The following is a description of a gene set: Genes having at least one occurrence of the motif RWAAACAANNN in the regions spanning 4 kb centered on their transcription starting sites. This matches the MLLT7 transcription factor binding site V$FOXO4_01 (v7.4 TRANSFAC). studied in species Homo sapiens Human Gene Set: FOXO4_01, and this is the list of marker genes: CACNA2D2, SZT2, TRERF1, DPH1, LMO4, CSNK1G3, EPN1, ADGRL2, SH3GL3, TRPM3, WFIKKN2, CADM2, EZH1, MSMB, HOXB8, MIDEAS, RBL2, CBFA2T2, SLITRK5, INHBA, BRD8, SNCAIP (synuclein alpha interacting protein), LINC00173, NFIB, HCAR3, STX16, ADGRL1, LRRC1, HHIP, KRT86, MEIS2, RASD1, NDRG1, PURA, RASSF6, FGF14, PTCH1, POLR2L, NFATC3, MTMR2, HOXB4, DCAF11, TM9SF3, LRRTM3, PITPNC1, TAF5, PCDHB15, HR, CSMD3, KDM3A, NR3C1, PXK, LUC7L3, DENND2B (NCBI Gene Id 6764), PAQR9, ABLIM3, HOXC10 (NCBI Gene Id 3226), HOXC4, THRA, EXT1, ZFYVE9, SLC12A6, HCAR2, CNPPD1, NEO1, LINC03122, GATA6, NRG1, CPNE1, ITGA1 (NCBI Gene Id 3672), HESX1, VASN, ZNF366, PRKAG1, RTL9, PALM, CEP120, LZTS2, ENPP2, FAM53C, PRDM1, TXNDC12, FGF9, SLC4A4, BIK, ASXL1, IL6ST, IRS4, SLC36A2, PTH1R, TBCC, RP1, CEP83, ID2, AP1G2, HOXA10, VLDLR, TJP1, OLIG3, MARCKSL1, HDAC9, KLF12, FST, PELO, ADAM12, SESN3, DHRS3, ETV5, PLAG1, RBMXL2, TLX3, EIF4G1, AKAP10, RANBP10, CREBRF, ZHX2, ISL1, C12orf50, COL8A1, KIF20A, ZBTB18, MAML3, RUNX1, PDCD4, TSPAN13, AZI2, SLC10A7, SATB2, KDM6A, RETREG2, ARRDC3, TSPAN4, CACNG2 (NCBI Gene Id 10369), NMNAT2, GPR18, EPHB1, PTP4A3, MAP3K3, FSTL1 (follistatin like 1), RARA, H3-3B, BDNF, SMURF2, VIT, ETV4, NDST4, PTCHD1, PTCHD4, MBNL1, TOP1, OTX2, ARHGEF38, IMPDH2 (inosine monophosphate dehydrogenase 2), ATOH8, C1QTNF3, FOXG1, CRTC2, CHCHD7, CCN1, GPR137B, KMT2E (lysine methyltransferase 2E (inactive)), ATXN7L1, CELF6, KY, DST, BCL11B, ATF7IP, INSRR, NYAP1, MSC, SLC26A7, SHOX2, CALM2, PDE4D, ABCC5, CADPS, TJP2, FCHSD2, ZNF385B, MPC2, UBE2H, ASIC2, SKAP1, ANKRD28, IMMP2L, PTGR3 (NCBI Gene Id 284273), SSBP3, TGIF1, CREBL2, FRMD4A, DDIT4, SALL3, HOXC6, LDB2, NAP1L5, LIMK2, DMD, FOXP2, H2AZ2, ALDH1A2, TBX4, KLHL40, TNFSF4, PHOX2B, HEBP2, ZNF521, HOXA11, WBP2NL, TMEM204, MXI1, KCNJ15, ETV1, CITED2, MECOM, FUZ, PFKFB3, EFCAB3, DBNDD2, CRB1, PLCB2, MAFF, WBP1L, ZNF654, C1orf43, ORC4, ZNF581, FOXP3, CBX2, CASC2, NIM1K, COLEC10, ERG, IKZF2 (NCBI Gene Id 51173), PROX1, ZNF580 (zinc finger protein 580), LZTFL1, NTRK3, ARHGAP30, SH3BP5, OTUD7B, KRT85, TPD52L3, SLC25A28, TRPS1, IL25, MED8 (mediator complex subunit 8)